Given this list of marker genes FANCG, FRAS1, DHCR7, BRIP1, FGF10, FANCD2, FGFR3, WT1, CCNQ, PALB2, UBE2T, FANCA, BRCA2, MNX1, HOXA13, FANCL, STRA6, RAD51, SF3B4, BRCA1, TBX3, FANCI, FANCB, SPECC1L, RAD51C, FOXF1, FANCF, FANCC, HNF1B, PIGN, SLX4, RFWD3, SETBP1, RARB, ALG9, RIPK4, MID1, FREM2, LARS2, FANCE, ERCC4, LRP2, XRCC2, FGFR2, WNT4, GRIP1, MAD2L2 (mitotic arrest deficient 2 like 2), FANCM (NCBI Gene Id 57697), ITGA8, TNXB, ESCO2, SRY, here is a description of the gene set: studied in species Homo sapiens Bicornuate uterus Human Gene Set: HP_BICORNUATE_UTERUS The presence of a bicornuate uterus.